Given this list of marker genes Trpc7, Dgkz, Prkce, Itpr3, Prkcd, Mgll, Dgki, Daglb, Abhd6, Dgke, Itpr1, Dagla, Dgkh, Prkcq, Dgkq, Prkch, Trpc6, Abhd12, Dgkd, Dgkk, Dgkb, Itpr2, Dgka (NCBI Gene Id 13139), Dgkg, Trpc3, here is a description of the gene set: Effects of PIP2 hydrolysis Mouse Gene Set: REACTOME_EFFECTS_OF_PIP2_HYDROLYSIS species: Mus musculus